Given this list of marker genes CCT2 (chaperonin containing TCP1 subunit 2), EIF4H, BANF1, HSP90AA1, SNRPE, PHB2, RHEB, HNRNPC, GANAB, DRG1, CYC1, TUFM, POLR2I, SOD1, CCT3, HMGN1, STARD7, COX7B, SNRPG, XRCC6, UBA2, IFT25, NDUFA1, PARK7, STOML2, UTP18, ATP5MF (NCBI Gene Id 9551), RALY, YWHAB, NEDD8, HNRNPA3P1, KARS1, NME1, HNRNPUL1, HSPD1, ERH, PSMA4, SRP14, PSMB4, SNRPB2, YWHAZ, ATP5MC1, CCT7, MDH1, SUMO3, ELOC, EEF1E1, SUMO2, COX5B, CALM2 (NCBI Gene Id 805), PSMB1, CSNK2B, RAN, ATP5F1C, CBX3, UQCRB, COX4I1, SNRPB, PUF60, SRSF9, NCL, EIF3K, DEK, HPRT1 (hypoxanthine phosphoribosyltransferase 1), CNBP, SRSF3, SET, PSMD8, COX7C, H2AZ2, EIF4A1 (NCBI Gene Id 1973), PSMC1 (proteasome 26S subunit, ATPase 1), YWHAQ, NDUFAB1, BZW1 (NCBI Gene Id 9689), NONO (non-POU domain containing octamer binding), NDUFA2 (NCBI Gene Id 4695), U2AF1, ACP1, JTB, COX6A1, PSMA2, PDCD6, COPS5 (NCBI Gene Id 10987), DDX49, PSMB3, ACLY, UQCRH (ubiquinol-cytochrome c reductase hinge protein), DYNLL1 (dynein light chain LC8-type 1), UBE2I (NCBI Gene Id 7329), POLR2G, HDAC1, SRP9, GDI2, TRIM28, UBE2L3, PSMB7, SLC25A3, PRDX1, PCNA, NARS1, SNRPD2, ATP5MC3, UQCRFS1, PRMT1, EIF3C, NDUFS3, HAX1 (HCLS1 associated protein X-1), YY1, KXD1 (KxDL motif containing 1), RNPS1, COX6B1, CDC123, C1QBP, STRAP, here is a description of the gene set: Neighborhood of ERH enhancer of rudimentary homolog (Drosophila) in the MORF expression compendium Neighborhood of ERH Human Gene Set: MORF_ERH species: Homo sapiens